The following is a description of a gene set: species: Homo sapiens A region of an axon near a node of Ranvier that is between the paranode and internode regions. Human Gene Set: GOCC_JUXTAPARANODE_REGION_OF_AXON, and this is the list of marker genes: EPB41L3, DLG2, KCNAB2, KCNAB1, SPTBN4, LGI3, KCNA2, CNTNAP2, SIRT2, CNTN2, DLG4, KCNA1